Given this list of marker genes Stat3, Yap1, Il6, Fer, C1qtnf4, Tut4, Gfi1, Cebpa, Spi1, Gab1, Ripk1, Smad4, Il6st, St18, Ptpn2, Src, Il6ra, Ctr9, Jak1, here is a description of the gene set: The series of molecular signals initiated by interleukin-6 binding to a receptor on the surface of a target cell, and ending with the regulation of a downstream cellular process, e.g. transcription. Mouse Gene Set: GOBP_INTERLEUKIN_6_MEDIATED_SIGNALING_PATHWAY studied in species Mus musculus